Given this list of marker genes POLR3B, POLR3E, POLR3F, GTF3A, GTF3C6, POLR3K, GTF3C1, POLR1C (NCBI Gene Id 9533), CRCP, POLR2E, POLR2K, POLR3D, POLR3A, GTF3C5 (NCBI Gene Id 95853), BDP1, POLR3H, POLR3C (RNA polymerase III subunit C), BRF1, POLR2F, POLR3G, POLR1D, POLR2H, GTF3C3, POLR2L, GTF3C2, TBP, GTF3C4, POLR3GL, here is a description of the gene set: species: Homo sapiens Human Gene Set: REACTOME_RNA_POLYMERASE_III_TRANSCRIPTION_INITIATION_FROM_TYPE_1_PROMOTER RNA Polymerase III Transcription Initiation From Type 1 Promoter